Given this list of marker genes EPRS1, COX8A, S100A4, KLHL40, EIF3A, NPNT, SGCA, SRSF3, EEF1D, EIF4E, C1QTNF3, GAPDH, CHAF1A, RRM2, RPL15, UNC45B, MARK2, APLP2, SLC25A6, PDPK1, NCAM1, DDX39A, USP10, RFC5, EIF2S1, RPS6KB1, KPNB1, PLP2, GATM, IGF1R, TPM1, EIF4G2, PPP2CA, NDUFS3, LBR, RPS6, EPS15, SUPT16H, STYXL2, HSPB2, UQCRH, PRKAG3, VBP1, FMO1, IFRD1, HDAC11, NEIL1, TNNC2, TKT, DDC, ENAH, PRDX6, CAVIN2, PSMA6, TTN, ABCA3, KHSRP, PGAM2, CTPS1, EBNA1BP2 (NCBI Gene Id 10969), HPCA, TMEM38A, H3-3B, HNRNPC, PSMB2, ACTN3, PTP4A2, DOCK2, HMGN2, POLR2C, BCAP29, POLR2H, ANP32B, EIF4A1, ATF4 (NCBI Gene Id 468), TNNT1, USP2, ZBTB18, ITPKA, POLD2, MKNK1, BARD1, HMGA1, EIF2S3, EIF2B5, FBL, MCM7, FBXO17, XIRP1, MYL4, ATP5MC3, ACAA2, ITGB1BP2, RPL36, SEC61A1, EIF4G1, MYBPH, PARM1, PKMYT1, EIF4EBP1 (NCBI Gene Id 1978), RPL29, PPP2R2A, MAPKAPK3, HMGB2, GSK3B, MX2, NOP16 (NOP16 nucleolar protein), RAB14, DCLK1, TCP1, FBXL22, PKIA, SFPQ, AP3S1, EIF4B, TXN, RPL4, LST1, here is a description of the gene set: 'Cancer prone response profile' (CPRP): genes common to estradiol and bisphenol A response of epithelial cell cultures from patients at high risk of breast cancer. Human Gene Set: DAIRKEE_CANCER_PRONE_RESPONSE_BPA_E2 from publication Dairkee SH, Seok J, Champion S, Sayeed A, Mindrinos M, Xiao W, Davis RW, Goodson WH (PMID 18381411) species: Homo sapiens Breast cancer outcome is highly variable. Whether inadvertent exposure to environmental xenobiotics evokes a biological response promoting cancer aggressiveness and a higher probability of tumor recurrence remains unknown. To determine specific molecular alterations which arise in high-risk breast tissue in the presence of the ubiquitous xenoestrogen, bisphenol A (BPA), we used nonmalignant random periareolar fine-needle aspirates in a novel functional assay. Early events induced by BPA in epithelial-stromal cocultures derived from the contralateral tissue of patients with breast cancer included gene expression patterns which facilitate apoptosis evasion, endurance of microenvironmental stress, and cell cycle deregulation without a detectable increase in cell numbers. This BPA response profile was significantly associated with breast tumors characterized by high histologic grade (P < 0.001) and large tumor size (P = 0.002), resulting in decreased recurrence-free patient survival (P < 0.001). Our assays show a biological fingerprint of probable prior exposure to endocrine-disrupting agents, and suggest a scenario in which their presence in the microenvironmental milieu of high-risk breast tissue could play a deterministic role in establishing and maintaining tumor aggressiveness and poor patient outcome.